The following is a description of a gene set: part of: Visual phototransduction species: Homo sapiens Reactome Pathway: The canonical retinoid cycle in rods (twilight vision) The retinoid cycle (also referred to as the visual cycle) is the process by which the visual chromophore 11-cis-retinal (11cRAL) is released from light-activated opsins in the form all-trans-retinal and isomerized back to its 11-cis isomer ready for another photoisomerization reaction. This process involves oxidation, reduction and isomerization reactions and take place in the retinal pigment epithelium (RPE) and photoreceptor segments of the eye (von Lintig 2012, Blomhoff & Blomhoff 2006, von Lintig et al. 2010, D'Ambrosio et al. 2011). This section describes the retinoid cycle in rods during dark/twilight conditions., and this is the list of marker genes: LRAT, RDH12 (retinol dehydrogenase 12), RHO, MYO7A, HSD17B1, RLBP1, TTR, RPE65, DHRS9, RDH11, RDH8, RBP1, RBP3, ABCA4, SDR9C7, RDH5, RDH10, RDH16, CYP4V2, HSD17B6 (NCBI Gene Id 8630), RBP4, STRA6